The following is a description of a gene set: studied in species Homo sapiens Human Gene Set: HP_ALVEOLAR_CELL_CARCINOMA Alveolar cell carcinoma Adenocarcinoma of the Bronchus., and this is the list of marker genes: SFTPC, ERBB2, ERCC6, EGFR, CYP2A6, BRAF, PRKN, CASP8, FASLG, KRAS, PIK3CA, PPP2R1B (NCBI Gene Id 5519), SLC22A18 (solute carrier family 22 member 18), MAP3K8, MUC5B, SFTPA2, IRF1, TERT